Given this list of marker genes Nop58, Ddx21, Riok3, Rpl12, Utp4, Pes1, Fau, Rps17, Rrp7a, Rpl37rt, Senp3, Rps26, Rps12 (ribosomal protein S12), Rps10, Rps6, Ltv1, Nop56, Rps15, Nol11, Rrp36 (NCBI Gene Id 224823), Xrn2, Gnl3, Rpl19, Rps28, Mtrex, Rrp9, Pno1, Rps3a1, Rpl6, Nop14, Rpl37a, Rps8, Rpl7, Rps9, Rps18, Rpl18, Rpl36al, Rps7, Rplp2, Eri1, Csnk1e, Fbl, Rpl24, Rps23, Rpl15, Rps19, Dcaf13, Rps5, Rpl39, Fcf1, Rpp25, Emg1, Rps4x, Wdr43 (WD repeat domain 43), Utp6, Rpl39l, Rpl3l, Rps27l, Rpl37, Ddx52, Rpl4, Ubb, Nob1, Rps24, Rps20, Pelp1, Snu13 (SNU13 homolog, small nuclear ribonucleoprotein (U4/U6.U5)), Rpl38, Rpp21, Rps11, Rpl29, Rpl36a, Bud23, Rpl11, Rpl9, Rpl18a, Rpp14, Rps2, Las1l, Rpl27, Rps13, Exosc10, Rpl27a, Rps25, Utp11, Rpl23a, Rpl3, Rpl13, Rpl26, Rpl14 (ribosomal protein L14), here is a description of the gene set: electronically inferred by orthology from the curated human pathway studied in species Mus musculus Reactome Pathway: Major pathway of rRNA processing in the nucleolus and cytosol This event has been computationally inferred from an event that has been demonstrated in another species.<p>The inference is based on the homology mapping from PANTHER. Briefly, reactions for which all involved PhysicalEntities (in input, output and catalyst) have a mapped orthologue/paralogue (for complexes at least 75% of components must have a mapping) are inferred to the other species. part of: rRNA processing in the nucleus and cytosol